Given this list of marker genes MYF5, HOXD9, SATB2 (SATB homeobox 2), OSR1, HOXA9, IFT140, SIX1, RUNX2, MDFI, HOXA7, HOXB4, CTNNB1, HOXC4, MYCN, FGFR2, HOXB9, COL11A1, HOXB5, EYA1, HYAL1, NIPBL, ALX1, ALX3, SMAD3, DYNC2I1, SLC39A1, HOXD4, MTHFD1, HOXB6 (homeobox B6), PDGFRA, TBX15, EIF4A3, FUZ, DSCAML1, FGF8, ALX4, HOXD11, TBX1 (T-box transcription factor 1), MEGF8, HOXA4, SIX4, PAX5, BMI1, HOXA3, HOXB2, TGFBR2, LHX1 (LIM homeobox 1), WNT9B, DLX2, MMP14, FOXC2 (forkhead box C2), HOXA1, HOXA11, SLC39A3, GRHL2, MED12, HOXD3, COL2A1, OSR2, NDST1, MMP16 (matrix metallopeptidase 16), IRX5, BMP7, TGFBR1, TWIST1, GLI3, ZEB1, FLVCR1, HOXA2, TFAP2A, PRRX1, SHOX2, NODAL, MTHFD1L, CHST11, SOX11, GSC, HOXD10, HOXB1, WDR19, RDH10, HOXC11, HOXB8, SMAD2 (SMAD family member 2), HOXB3, BMP4, NOG, DLG1, PCGF2, HOXB7 (NCBI Gene Id 3217), SIX2, TULP3, HOXA5, HOXC9, here is a description of the gene set: The process in which the anatomical structures of the skeleton are generated and organized during the embryonic phase. Human Gene Set: GOBP_EMBRYONIC_SKELETAL_SYSTEM_MORPHOGENESIS studied in species Homo sapiens